Given this list of marker genes PDE4DIP, RNF4, MISP, CLASP2, SLAIN1, SVIL, ABRAXAS2, KIF2C, DCTN1, SPRY2, SLAIN2, CLIP1, CAMSAP3, NCKAP5, SPAG5, CLIP2, DST, KIF18B, CLIP3, CKAP5, GAS2L1, GAS2L2, NUMA1, NCKAP5L, NAV3, TBCB, ASPM, CLASP1, KNSTRN, CAMSAP1, MAPRE2, CLIP4, MAPRE3, CAMSAP2, CDK5RAP2, MAPRE1, here is a description of the gene set: studied in species Homo sapiens Human Gene Set: GOCC_MICROTUBULE_END Any end of a microtubule. Microtubule ends differ in that the so-called microtubule plus-end is the one that preferentially grows by polymerization, with respect to the minus-end.